The following is a description of a gene set: Pathway Definition from KEGG: EREG -> EGFR -> PI3K -> PIP3 -> AKT -> MTOR -> S6K Human Gene Set: KEGG_MEDICUS_REFERENCE_EREG_EGFR_PI3K_SIGNALING_PATHWAY studied in species Homo sapiens EREG-EGFR-PI3K signaling pathway. Pathway ID: N00282. Pathway type: Reference. Pathway class: nt06260 Colorectal cancer., and this is the list of marker genes: PIK3CB, MTOR, RPS6KB2 (NCBI Gene Id 9017), PIK3CA, AKT1, EGFR, RPS6KB1, EREG, AKT2, AKT3, PIK3CD